The following is a description of a gene set: Human Gene Set: WP_VALPROIC_ACID_PATHWAY Valproic acid pathway studied in species Homo sapiens, and this is the list of marker genes: HADHA (NCBI Gene Id 3030), ABAT, HSD17B10, HADHB, HDAC1 (NCBI Gene Id 3065), EHHADH, CYP2A6, CYP2C9, ACSM1, IVD, CYP2B6, ACADSB